The following is a description of a gene set: from publication Rickman DS, Millon R, De Reynies A, Thomas E, Wasylyk C, Muller D, Abecassis J, Wasylyk B (PMID 18679425) Up-regulated genes that vary between HNSCC (head and neck squamous cell carcinoma) groups formed on the basis of their level of pathological differentiation: well vs poorly differentiated tumors. Propensity for subsequent distant metastasis in head and neck squamous-cell carcinoma (HNSCC) was analysed using 186 primary tumours from patients initially treated by surgery that developed (M) or did not develop (NM) metastases as the first recurrent event. Transcriptome (Affymetrix HGU133_Plus2, QRT-PCR) and array-comparative genomic hybridization data were collected. Non-supervised hierarchical clustering based on Affymetrix data distinguished tumours differing in pathological differentiation, and identified associated functional changes. Propensity for metastasis was not associated with these subgroups. Using QRT-PCR data we identified a four-gene model (PSMD10, HSD17B12, FLOT2 and KRT17) that predicts M/NM status with 77% success in a separate 79-sample validation group of HNSCC samples. This prediction is independent of clinical criteria (age, lymph node status, stage, differentiation and localization). The most significantly altered transcripts in M versus NM were significantly associated to metastasis-related functions, including adhesion, mobility and cell survival. Several genomic modifications were significantly associated with M/NM status (most notably gains at 4q11-22 and Xq12-28; losses at 11q14-24 and 17q11 losses) and partly linked to transcription modifications. This work yields a basis for the development of prognostic molecular signatures, markers and therapeutic targets for HNSCC metastasis. species: Homo sapiens Human Gene Set: RICKMAN_TUMOR_DIFFERENTIATED_WELL_VS_POORLY_UP, and this is the list of marker genes: OGT, ROBO1, VARS2, SLC25A6, SIM2, NAP1L1 (nucleosome assembly protein 1 like 1), STARD7, ALDH2, CCDC28B, XPO1, MECOM, MYCN, LRRC14, ZNF180, SYNPO2, SEMA6A, HNRNPU, MEX3A, CENPV, RPS7, MYNN, CD8B, SRSF7, GMCL1, AHSA2P, GPR161, TERF1, FZD7, LIFR, KLHL12, MED12, ZBTB39, DDX17, EML4, PHC1, HNRNPLL, RPL35A, CHD1L, POGZ, CAPS, SBK1, LGR6, ACSS1, CLDN11, MAP7D2, CSPP1, AGBL5, SHROOM3, MSH6, TARBP1, TRAF5, OPLAH, TMEM97, IPO9, ARHGAP19, OCA2, ACACB, CHCHD6, PHKA2, GATAD2B, ZNF875, SFXN2, ZNF747, FAM171A1, JRK, LIPT1, GNAS, IFT122, SMCHD1, ZNF251, MCM3, SLC5A6 (NCBI Gene Id 8884), LUC7L3, CABYR, CENPS, FRZB, BTN2A2, BOLA1 (NCBI Gene Id 51027), HOXC9, ZNF322, TRAF3IP3, SPAG5, MAN2A2, MAP2K6, PKDCC, ANP32A, NEO1, GLCCI1, TRA2B, MYB, NUCKS1, ZNF496, ANKRD46, H1-10, ATP6V0E2, CCT6P3 (NCBI Gene Id 649553), FBL (fibrillarin), COMMD7, TNRC18, E2F5, ISYNA1, PBX1, TENT4A, FUBP1, MDH1, AGO2, ECHDC2, EFHC1, CENPF, EEF1D (NCBI Gene Id 87167), SFT2D3, H4C3, ABHD12, EMID1, GFPT1, SFPQ, OARD1, PLCB4, MSI2, IRF2BP2, CGNL1, ERO1B, PKP4, SRSF3, TSPOAP1, CACYBP, ZNF764, PTCH1, EPB41, FLVCR1 (NCBI Gene Id 559), LRP6, NFYA, RBM39, ATP5F1A, TOMM20, NCOA5, POLR2B, NOP53, GCFC2, SCARA3, FARP1, TMEM70 (transmembrane protein 70), B3GALNT1, SOS1, PPM1B, ZNF704, MDM4, ETV5, NPB, ASB3, SRSF1 (NCBI Gene Id 650453), CCL19, TOMM70, TNRC6C, GCNT2, FRMD4A, TTLL4, SRSF6, ACVR2B, UCK2, SNCAIP, E2F6, LPIN1, LTB, TMPO, MVB12B, C5, ITGB2-AS1, CCT3, ALDH1A1, FAM118A, SPRY2, CEP70, FAM13B, CCDC74A, USP21, RPL5 (NCBI Gene Id 90045), PARP1, RPL23, GINS1, PSMB4, GSTM4, MGAT3, TGS1, MTMR1, NR2F1, CCT7 (NCBI Gene Id 10574), SMC4, ZBED5, RPS27, NINL, C2orf68, LBR, SNHG6, RMI2, SLC45A4, NCOR1, TRAPPC6A, SNRNP200, FAM117A, NCBP2, NEPRO, RPL17, MUTYH, EARS2, SRRT, SNRPE, SEPHS1, ATP5MC2, GTF3A, PNISR, EIF3L, MAT2A, ABI2, CREB3L4, BCL11A, IMMT, DNMT3A, NEMP1 (nuclear envelope integral membrane protein 1), ZCCHC3, RPIA, ZNF740, ATP2C1, AHCTF1, TFDP2, IARS2, TRAF4, CLASRP, WBP1, TGIF2, CBFA2T2, CHPT1, NONO, NASP, MSL2 (MSL complex subunit 2), ATF7IP2, RABL2B, PDCD4, ARHGEF26, LMO4, BCL7A, UBE2T